The following is a description of a gene set: mouse primary BMDCs were stimulated with tlr ligands and gene expression changes were profiled on Affymetrix arrays from publication Amit I, Garber M, Chevrier N, Leite AP, Donner Y, Eisenhaure T, Guttman M, Grenier JK, Li W, Zuk O, Schubert LA, Birditt B, Shay T, Goren A, Zhang X, Smith Z, Deering R, McDonald RC, Cabili M, Bernstein BE, Rinn JL, Meissner A, Root DE, Hacohen N, Regev A (PMID 19729616) Genes up-regulated in comparison of dendritic cells (DC) stimulated with poly(I:C) (TLR3 agonist) at 4 h versus DC cells stimulated with Gardiquimod (TLR7 agonist) at 4 h. species: Homo sapiens Human Gene Set: GSE17721_POLYIC_VS_GARDIQUIMOD_4H_BMDC_UP, and this is the list of marker genes: NUP88, RBM47, GSDMC, NAT1, ILRUN, CTDSP2, TSTD1, EVI5, RNF123, IDH1, EMID1, CPEB3, PLCL2, NCAPD2, BIRC6, PRKDC, CORIN (corin, serine peptidase), N4BP3, SVBP, TRAPPC14, TMEM209, DCTPP1, PDK3, AFMID, ITSN2, BRD2, MPST, VPS26B, RB1, CAAP1, CCDC80, CALHM2, ABCG1, ELMO2 (NCBI Gene Id 63916), STMN1, ARHGAP45, NDRG4, TIMELESS, RACGAP1, RNPEPL1, MDP1, NT5C3A (NCBI Gene Id 96002), SNAP29, PFDN1, OR5D18, ANAPC13, RASA4, ATP8A1, NDUFS3, FABP4 (fatty acid binding protein 4), UBE2R2, ACADS, SMC5, ARHGAP18, VARS1, FTL (ferritin light chain), RIPK3, CDH3, TOMM6, KRTCAP2, APOBEC3B, IRF7, PITPNC1, GTPBP2, TAF6L, NUP153 (nucleoporin 153), PIAS1, NDUFB11, FLI1, STOM, ADIPOR2, SECTM1, C8orf33, GPT2, AKAP9, NAXE, KAT2A, SLC25A22, KLF6, MEIS3, MRI1, N4BP2L1, CHCHD7, PRPSAP1, SERINC3, MBD1, TOMM70, CFI, NKX2-2, HEMK1, FGF13, NCAPG2, FHDC1, SLC38A1, NUDT9, ATP6V1D (NCBI Gene Id 51382), BTBD2 (BTB domain containing 2), CPSF2, PHKA2 (phosphorylase kinase regulatory subunit alpha 2), DAP3, PLPP7, MITF, RNF34, RNF19B, NEK9, ATP13A1, CCNJ, WNT11, ADAMTS15, CDCA5, DDX60 (DExD/H-box helicase 60), SNW1, COMT, ABCD2, PHLDA2, ATP5IF1, HLA-B, CABP7, TPCN1, STAT4, TMTC4, EPRS1, PTS, CAMK1D, MTIF2, GGA2, OSBPL2, GJD2, PDXK, TMEM229B, NEK7, MYCBP2, RGS14, INPP4A, PRPF38A, HDAC1, RERE, PDCL2, FBXO25 (NCBI Gene Id 26260), NECAP2, ETHE1, SRPK2, PLCB2, SLC52A3, PKIB, PTPRN (NCBI Gene Id 5798), SAT1, PCYT1A, ZFYVE26, YAP1, CD244, IFIH1, CCNG2, BIN3, GDI2, RPS11, MYO7A, MIA2, TEX2, NUDT13, NXF1, MXI1, VPS37B (VPS37B subunit of ESCRT-I), CPSF3, MAGEL2, SLC12A9, RPS25, MPV17, ITPRID2, RNF187, HFE, BRDT, MBD2 (NCBI Gene Id 8932), BLMH, PLPP2, OAS2, RMDN3, IFT27, PPCDC, EXTL2, BIRC2, PRR15, TCF12, ANGPTL2, ASNS, COX18, RBBP8, BATF2, CBX7, SAMD10, PSMD4, HASPIN, RSAD2, PAXBP1, PRCP, AKAP12, TBCD, RPP21, GPSM2, MAU2